The following is a description of a gene set: species: Homo sapiens Human Gene Set: MODULE_346 Genes in the cancer module 346., and this is the list of marker genes: PRDX6, UGCG, SMPD1, PLD1, ASAH1, PLCG2, GM2A, PLCD1 (phospholipase C delta 1, NCBI Gene Id 5333), B4GALNT1, IMPA1, HEXA, PLA2G5, GPX4, ARSA, PSAP, NSMAF, HEXB